Given this list of marker genes Pola2, Prim1, Pola1, Ppp2r1b, Rb1, here is a description of the gene set: species: Mus musculus part of: G1/S Transition This event has been computationally inferred from an event that has been demonstrated in another species.<p>The inference is based on the homology mapping from PANTHER. Briefly, reactions for which all involved PhysicalEntities (in input, output and catalyst) have a mapped orthologue/paralogue (for complexes at least 75% of components must have a mapping) are inferred to the other species. Reactome Pathway: E2F mediated regulation of DNA replication electronically inferred by orthology from the curated human pathway